Given this list of marker genes RNF103, COPE, HBE1, MAGED4B, CLUH, BFSP2-AS1, BRAP, NRL, TMCC2, TLN1, FMN1, INIP, LPL, ATG4D, PYCR3 (NCBI Gene Id 93098), NGF, EFCC1, MED28, REV3L, PLEKHG1, BSDC1, LRRC19, PCED1B, TRIM7, OTOR, SLC19A1, PPP1CB, BCL2L14 (BCL2 like 14), MST1R, VIT, NME1, PPP4R2, ACKR1, TMEM250, CIP2A, ADAMTS3, ERVMER34-1, DNAH11, FAIM, MAPKBP1, BCR, DNAJB9, CEBPZ, LRRC4C, PTX3, PAWR, SLC39A8, LY86, MICALL1, CAND1, PLEKHF2, PNMA8A, NUP54, LRRC14, ZKSCAN7, LYZ, TNFRSF13C, CST1, CNOT6L, DZIP3, ZNF264, PLIN1, HOMER2, CBLN1, SARAF, CYP1A1, STRIP2, MAP2K6, DHODH, GEM, TMEM255A, C19orf73, EPS15L1 (NCBI Gene Id 58513), SAV1, ATP8A2, UFSP2, STAT3, ZNF143, LEPROTL1, RNF213, IPCEF1, ELAC1, SNRNP25, PORCN, AMZ2, KLHL41, GSTM1, GLB1L, GM2A, ACVR1, VNN1, CCL2, ZBTB5, KATNIP, TAL1, LNPK, ZNF117, PHIP, CDH4, RBM7, BTN2A1, CUL9, TMEM62, AHNAK, TNFSF4, POU6F2, ZMYM5, SCD, NCF2, ANKRD13A, ZMAT4, TIMP4, HS1BP3, POLDIP3, ACSM5, PGLYRP2, PCGF1, LAP3 (NCBI Gene Id 5186), SLMAP (sarcolemma associated protein), WDR19, DCTN3, ART3, EPHA7, PTPRT, DEXI, ITGAM, NADSYN1, SLC25A27, BPTF, SOX21, PDCD6, OSBPL9, EIF2B4 (eukaryotic translation initiation factor 2B subunit delta), XPO4, UGCG, HIVEP2, GOLGA5, PPP2R2C, DIO3, GJA5, ASXL2, TMEM97, SQOR (NCBI Gene Id 58472), TFPI2, ALG6, CHD1, MLYCD, ZNF107, NEPRO, PHAX, LRP3, DPYD, FAM220A, XRN2, RPAP3, QSER1, COL6A3, PPP1R14D, MYEF2 (myelin expression factor 2), FGD6, CORIN, ERMN (NCBI Gene Id 57471), ELOB, SLC22A3, SH2B3, NECAP2, IL1RL1, NELFB (negative elongation factor complex member B), TUBA4A, GSN, CMTM6, FURIN, SP140L, TMEM121B (NCBI Gene Id 27439), FNBP4 (formin binding protein 4), BEGAIN, ZGRF1, MMP14, KLHL4, WDR46, PYGB, ERLIN2, CEP162, TMEM47, MCTS1 (NCBI Gene Id 28985, MCTS1 re-initiation and release factor), CXCL8 (NCBI Gene Id 3576), ABI3, DYNC2LI1, EREG (epiregulin), LGALS3BP, IL1R2, ATRN, LANCL2, IL13RA1, KAT2B, LARP1, MXRA8 (NCBI Gene Id 84308), COCH, SIPA1L3, FGFR1, TRABD, GREB1, GPR68, MRPL47, ALDH1B1, SPMAP2, MED12L, NANS, KCNE4, CLCF1, NSUN3, AURKAIP1, MTMR12, GABARAPL2, RRAGD, CYYR1, S100A5, OXGR1, TMEM120A, LACTB, ACE, NCOA7, TOR4A (NCBI Gene Id 54863), ANKFY1, EPCIP, C17orf75, IMMT, TP53, NHSL3, COQ8A, PI4K2B, YWHAB, AKAP8L, HMGN5, CCDC81, IGKC, MRPL27, EPB41L4B, CHST9 (NCBI Gene Id 83539), DLC1, FAR2, SV2B, EEF1D, SENP1, ZFP41 (ZFP41 zinc finger protein), POGLUT2, TMT1A, CNKSR2, EARS2 (glutamyl-tRNA synthetase 2, mitochondrial), TMEM144, ACSL1, NEIL1, CDH22, FAF1, NUP58, EYA3, AMOTL2, USP36, ARHGAP45, CELF2, LMTK3, CDK16, SLC26A8, ZDHHC2, ARID5A, PITPNC1, FN1, CSF1, BAG3, GABPB1-IT1, KIF18A, MREG, DCLK1, ATXN7, BGN, BASP1, CHD9, MOB4, TRIM48, CACNA2D3, TMED3, SMAD3, UNC79, TBC1D8B, PDE4D, FBXW4, ZNF318, TTF2, PLAAT4, AMY2B, CDK11A, ACTR6, DNAAF4, SNX5, CTSZ, ITGA4, TRIM14, GJC2, ALDOA, GJA1, MAPK4, SPSB4, RNASE6, OR2F1, HNRNPU, TMEM248, BPIFA1 (NCBI Gene Id 51297), RNF220, CD1A, PRDM1, CD163, TIMP3, ARHGAP20, CYP2A7, HNRNPDL, HACD1, CCDC90B, ZNF566, FBXO11, MMP9, LRRN3, TIMELESS, REPIN1, FPR2, SMG7, IWS1, ITGB1, CCAR2, TESPA1, KIAA2013, CXCL10, ADIPOR2, TDP1, PDCD2L, PARS2, GPATCH3, GRAPL-AS1, MCMBP, PLEKHM2, MPRIP, ARG1, SOX6, GPSM3, ILRUN, MFSD1, WDR25 (WD repeat domain 25), APTX, SLAMF7, RNASEL, WRNIP1, GEMIN7, ATG16L1, DES, TMLHE, GPR26, PIP4K2C, CCNL1, NUTM2F, DIRAS2, RERE, PLGLB2, OBSCN, CCBE1, CD8A, FABP2, CHL1, NOL7, IL18R1, MYL12A, SLC11A2, AASS, BAIAP3 (BAI1 associated protein 3), NXPH4, KDM4D, MOCOS, HIF1A, SEMA4A, EFS, SPNS1, ATG2A, PKIA, KDM5B, DNAJA1P5, MRPL18, SLC17A8, UTP11, STAMBPL1, IL1A, CD1D, FAM169A, ITM2C, LDAH, C1orf116, MMP7, OR7E12P (olfactory receptor family 7 subfamily E member 12 pseudogene), CELP, TMEM161A, NACAD, MRPL36, NFIL3, ALKBH4, MBD5, MORC3, CHST1, SIAH1, SCARA3, NOP53, TBC1D9, ANXA1, KATNAL1, DCAF15, CDH5, PTGS2, SLC43A1, ARHGAP15, LINC00160, KRT19, AMIGO1, NELFCD, ITGB5, LY9, PAPOLA, SSBP4, QKI, CCDC85C, KLHL36, ITK, EPHB6, ZCCHC4, MAL2 (NCBI Gene Id 114569), CCL11, FLJ13224, CCDC134, CSF2RB, PTPRF, CITED2, MED25, FOS, SFRP1, ABHD17C, SELP, NR2E1, MICB, RPRM, PIF1, TSLP, PTPRZ1, ELOVL2, DCANP1, OR2A1, MRPS15, PRPF39, BCL2L13, PRDM8, GOLGA4, FUCA1, INO80B, ISYNA1, STRN, AGAP2, DDX60, BRIP1, SUGP2, PAQR5 (NCBI Gene Id 54852), SDC3, ESPN, SLITRK1, LYL1, SURF6, here is a description of the gene set: Human Gene Set: MODULE_179 Blood cells and cancer expression cancer. species: Homo sapiens